Given this list of marker genes Fkbp15, Pik3r5, Extl1, Pla2g4a, Elovl3, Gga3, Dhx15, Ipmk, Kcnd3, Wdr47, Bbs4, Clca3a2, Ifit1, Pfkl, Serpina5, Srp9, Slc10a7, Tspan32, Phkg1, Stk4, Pabir2, Clca3a1, Ssr3, Pde10a (NCBI Gene Id 23984), Dock10 (dedicator of cytokinesis 10), Esco2, Thbd, Shisa7, Ago3 (NCBI Gene Id 320115), Negr1, Elovl1, Mtdh, Trim59, Mest, Mstn, Tspan14, Emc7, Rb1cc1, Lyrm1, Rsbn1, Esr1, Zfp326, Oprl1, Nup188, Amigo1, Hoxb9, Pter, Syncrip, Neu3, Sel1l3, Slco5a1, here is a description of the gene set: Mouse Gene Set: MIR_6988_3P from publication Chen Y, Wang X (PMID 31504780) species: Mus musculus Genes predicted to be targets of miRBase v22 microRNA mmu_miR_6988_3p in miRDB v6.0 with MirTarget v4 prediction scores > 80 (high confidence targets).